Given this list of marker genes ATP6V0E2, GOLT1B, RNASEH2C, WWP1, SNX4, NCBP3, APOL6, TOM1L2, FNIP2, GPR146, SFSWAP (NCBI Gene Id 6433), RLBP1, CCDC12, PHYHD1, PNISR, CRK, HLA-C, JOSD2, RANBP17, NTM, STRN3, NSD1, TCEAL1, LIPA, RBMXL1, DCTN2, PLEKHA4, ARHGEF6, AJAP1, CLMN, NIBAN2, PPP1R12C, ZNF532, N4BP2L2, CFL2, MAP2, LIPT1 (NCBI Gene Id 51601), CDC42EP5, PPP3CC, ZC2HC1A, CAT, COL5A3, NRDE2, CGRRF1, CD58, HCFC2, IFNAR2 (interferon alpha and beta receptor subunit 2), ADGRB3, CHRM3, MPG, OPN3, RIN2, UBE2D1, WDR47, MAP3K11, ANKZF1, FPGT, PCDH20, MOB2, TRMT13, GAB1, IZUMO4, WASL, FRMD3, ROBO3, KAT2B, KLF15, LBR, HYCC1, VSIR, G2E3, POMT1, EPN2, RAB40B, FRY, MAP2K7, CHORDC1, RRAD, RTKN, MMP17, IRF4, SYT11, CCP110 (centriolar coiled-coil protein 110), CREB1, ITPR3, COMMD3, PPP2R2B, TAFA5, WDFY1, LYSMD2, ADGRG6, here is a description of the gene set: Human Gene Set: GAUTAM_EYE_IRIS_CILIARY_BODY_SCHWANN_CELLS from publication Gautam P, Hamashima K, Chen Y, Zeng Y, Makovoz B, Parikh BH, Lee HY, Lau KA, Su X, Wong RCB, Chan WK, Li H, Blenkinsop TA, Loh YH (PMID 34584087) Occular cell types curated from Gautam and Hamashima et al. Multi-species single-cell transcriptomic analysis of ocular compartment regulons species: Homo sapiens